Given this list of marker genes GATA2, SRP54, THPO, NBN, STS, MSH2, RPS20, WIPF1, FLT3, LZTR1, PRKACB, ELANE, SAMD9L, ERBB3, BCR, HEATR3, XRCC4, EFL1, RPS15A, DNAJC21, NSD1, ADH5, RPL35A, RPL9, SRSF2, RPL8, KIT, RPS24, SRP19, RPS7, DUT, WAS, RPS27, NPM1, SBDS, RPS26, GATA1, TSR2, NSUN2, RARA, PRKACA, TRIP13, BUB1B, RPL26, DKC1, GFI1, RPS14, TCF3, DDX41, TP53, BLM, DNMT3A, MEFV, RPL31, RPS19 (NCBI Gene Id 8378), EVC, BRCA2, NUP214, SH2B3, ASXL1, APC2, BAX, RPL15, LIG4, MDM2, ABL1, GNB1, TYROBP, SAMD9, RPL18, MPL, RPS17, HAX1, IKZF1, IDH1, TAL1, ETV6, GLI1, RPL27, TCIRG1, ATRX, ADA2, UBE2T, MLLT10, TREM2, KRAS, BUB3, TERT, PICALM, BUB1, PIGL, TET2, MBD4, RPS28, LPP (LIM domain containing preferred translocation partner in lipoma), CEP57, SH3GL1, RPL11, PTPN6 (protein tyrosine phosphatase non-receptor type 6), SF3B1, SMPD1, CALR, RPS29, RPL5, EVC2, CLPB, JAK2, PALB2, CEBPA, RPS10, CHIC2, CHEK2, DYNC2LI1, ATM, RPL35, TAL2, CDKN2A, SPRED1, RUNX1, here is a description of the gene set: A clonal (malignant) hematopoietic disorder with an acute onset, affecting the bone marrow and the peripheral blood. The malignant cells show minimal differentiation and are called blasts, either myeloid blasts (myeloblasts) or lymphoid blasts (lymphoblasts). Human Gene Set: HP_ACUTE_LEUKEMIA Acute leukemia studied in species Homo sapiens